Given this list of marker genes GREM1, BCR, DUSP1, APOD, MICOS10-NBL1, RIPOR2, CD69, CNN2, BMP5, GCSAM, MMP28, DDT, CCL2, CD200R1, AKT1, KLRC4-KLRK1, C5, MIF, CCN3, MIR24-1, CYP19A1, STAP1, NBL1, KLRK1, MIR146A, EMILIN1 (elastin microfibril interfacer 1), CD200, SLAMF8, ADTRP, LRCH1, SLIT2, MIA3, PLCB1, IL27RA, MIR128-1, PADI2, WASL, here is a description of the gene set: Human Gene Set: GOBP_NEGATIVE_REGULATION_OF_MONONUCLEAR_CELL_MIGRATION species: Homo sapiens Any process that decreases the rate, frequency or extent of mononuclear cell migration. Mononuclear cell migration is the movement of a mononuclear cell within or between different tissues and organs of the body.